Given this list of marker genes RABGGTA, RABGGTB (NCBI Gene Id 5876), PTAR1, FNTA, CHM, here is a description of the gene set: Human Gene Set: GOMF_RAB_GERANYLGERANYLTRANSFERASE_ACTIVITY Catalysis of the reaction: 2 geranylgeranyl diphosphate + protein-cysteine = 2 S-geranylgeranyl-protein + 2 diphosphate. This reaction is the formation of two thioether linkages between the C-1 atom of the geranylgeranyl groups and two cysteine residues within the terminal sequence motifs XXCC, XCXC or CCXX. Known substrates include Ras-related GTPases of a single family and the Rab family. studied in species Homo sapiens